Given this list of marker genes Hspa1b, Hspa1a, Rgs1, Jun, Tacc1, here is a description of the gene set: from publication Cui A, Huang T, Li S, Ma A, Pérez JL, Sander C, Keskin DB, Wu CJ, Fraenkel E, Hacohen N (PMID 38057668) Genes negatively differentially expressed in cell type: Langerhans upon treatment with cytokine: IL-17D in mouse lymph nodes in vivo. studied in species Mus musculus Mouse Gene Set: CUI_LANGERHANS_IL17D_RESPONSE_DN Cytokines mediate cell-cell communication in the immune system and represent important therapeutic targets. A myriad of studies have highlighted their central role in immune function, yet we lack a global view of the cellular responses of each immune cell type to each cytokine. To address this gap, the authors created the Immune Dictionary, a compendium of single-cell transcriptomic profiles of more than 17 immune cell types in response to each of 86 cytokines (>1,400 cytokine-cell type combinations) in mouse lymph nodes in vivo. A cytokine-centric view of the dictionary revealed that most cytokines induce highly cell-type-specific responses. For example, the inflammatory cytokine interleukin-1β induces distinct gene programmes in almost every cell type. A cell-type-centric view of the dictionary identified more than 66 cytokine-driven cellular polarization states across immune cell types, including previously uncharacterized states such as an interleukin-18-induced polyfunctional natural killer cell state.